Given this list of marker genes DAZL, CXCL6, CDH9, EPB41L3, SLC2A10, TPR, MIR600HG, SOCS1, SULT1B1, LGALS14, LMO7, MSTN, NUDCD3, PIAS3, OR7E24, APOA2, DAPP1, RPL35, CASK, EAF2, MAB21L2, MGC4859, PLK2, ADRB2, ZNF280A, MYEF2, TPT1, LINC00667 (NCBI Gene Id 400642), EYA1, TASOR, SLAMF1, DMRT1, EIF5A2, HOXA11, FLG, PLCB3, LIG4, BIN2, WDR76, HMGCS1, PLK4, SORL1, KLF4, IGHD, ASAP1, ZPBP, CHFR, NXPH4, KRT6B, ALDH1A1, ZNF276, PBLD, MOGS, ART1, NEK3, KHDC4, PGS1, GDPD3, SSBP2, EFNB3, WBP11, SLC22A3, KDM7A, GYS2 (NCBI Gene Id 2998), IFT81, SYNE3, CRYBA4, ITPR3, TAS2R9, LINC01587, MLLT3, DCUN1D4, KLF7, CLIC4, SPRY1, MORC1, ZNF345, S100A10, CEP170B, WDHD1, GFPT1, NQO1, LARGE1, H2BC17, TUBB3, PLAAT2, TRIB2, SNAI2, AHCYL2, AHR, ADK, IL4R, FNDC11, DDX28 (DEAD-box helicase 28), SNTG2, BTN2A2, SATB1, SETD3, KLHL29, VHL, ITGB2, TCL1A, SLC6A6, ADH7, SLCO1B3, DGKI, MAPKAPK5-AS1, BCL6, SPC25, MEIS2, KIAA0040, LRRC8E (NCBI Gene Id 80131), VGLL3, DCLRE1B, MFAP3L, CORO2B, KIFAP3, WDR91, MAP4K3, DTX4, SRSF4, OPA1, ZNF395, KYAT1, RIMS1, WAC, IQCH, CDH3, OR10C1, RPL34, ZFPM2, ADCY10, DUX4L8, TCEAL2, TNFAIP3, CRIP1, TES, MYCT1, BHLHE40, ZNF473, RASGRF1, NFYA, THBS1, HIPK3, CEP131, PLPBP, ZNF606, ANKRD1, SAP30, BCO1, C19orf73, SYCP2, PKNOX1 (NCBI Gene Id 5316), PCDH9 (protocadherin 9), TSC22D3, BACH2, PNOC, EMP3, RAB36, GJC1, USH2A, HSPB1, RASGRP2, KCND3, DGKD, LPIN2, C1orf56, GVINP1, MAPK13, BAIAP2, SH3BP2, VEZF1, SKAP1, SOBP, OAZ1, PDCD6IP, EXPH5 (NCBI Gene Id 23086), ASGR2, JUN, NELFA, CD200, H1-1, BRINP2, GOLGA6A, CAPRIN2, SOX30, NAT8B, XK, CD52, PHF20L1, CHST15 (NCBI Gene Id 9916), TSPO, TRIO, PTPN21, DPF3, MMP28, here is a description of the gene set: from publication Good KL, Avery DT, Tangye SG (PMID 19124732) Enhanced secondary Ab responses are a vital component of adaptive immunity, yet little is understood about the intrinsic and extrinsic regulators of naive and memory B cells that results in differences in their responses to Ag. Microarray analysis, together with surface and intracellular phenotyping, revealed that memory B cells have increased expression of members of the TNF receptor, SLAM, B7 and Bcl2 families, as well as the TLR-related molecule CD180 (RP105). Accordingly, memory B cells exhibited enhanced survival, proliferation and Ig secretion, as well as entered division more rapidly than naïve B cells in response to both T-dependent and T-independent stimuli. Furthermore, both IgM and isotype switched memory B cells, but not naïve B cells, co-stimulated CD4+ T cells in vitro through a mechanism dependent on their constitutive expression of CD80 and CD86. This study demonstrates that upregulation of genes involved in activation, co-stimulation and survival provides memory B cells with a unique ability to produce enhanced immune responses and contributes to the maintenance of the memory B cell pool. Human Gene Set: GSE13411_NAIVE_VS_IGM_MEMORY_BCELL_UP species: Homo sapiens Genes up-regulated in comparison of naive B cells versus IgM-memory B cells.